Given this list of marker genes PPDPF, CTSD, CDK2, STMN1, HNRNPH3, HLA-DMA, ADD1, S1PR4, RCBTB1, HMCES, MTCH1 (NCBI Gene Id 51627), SUN2, SPA17, DOK2, PIP4K2A, GLIPR2, RAD51AP1, QSOX1, OXCT1, ARMCX2, SPATA13, ACOT9, KIF20A, NHERF1 (NCBI Gene Id 9368), APCDD1, KIF11, USP3, TMEM71, PQBP1, CDKN1B, HSD17B4, CAPG, TCF7, CTSA (cathepsin A), FRAT1, INTS9, CACUL1, VAMP8, FOXC1, ITM2A, PLS3 (NCBI Gene Id 5358), TIMM10B, NSMCE1, SMPDL3A, DDX19B, TRPV2, NCOA5, TMEM50B, NUDT16L1, INCENP, S100PBP, RPA1, NOP53, TLE4, ITGB7, DAP, RNF145, RAMAC, RAC2, ACP6, PDCL3, PLD3, RASA3, MCM2, SERBP1, RGS10, MGST2 (microsomal glutathione S-transferase 2), PROS1, ZNF277, MXD3, HSD17B10, CDADC1, OCEL1, KCNJ8, CASP6, BTBD1, CAVIN3, MYB, LTB, MCOLN2, ID3, XPR1, RPL34, PIK3R1, TBC1D23, CASP7, ENG, NRGN, TWF2, BTK (Bruton tyrosine kinase), TSPAN32, LSP1, CSTB, C19orf12, SARAF, NUCB1, KLKB1, RIPOR2, KDELR1, KLK8, PRKACB, FERMT2, RNF26, RPP21, PEX6, S100A10, PIGX, CCDC28B, GIMAP4, EIF3K, OAZ2, TNFAIP8L1, ARPC3, WBP1L, HDAC5, ANXA5, HCLS1, PDRG1, UBE2L3, HNRNPM, ASF1B, NAA38, UNG, BRK1, BUD31 (BUD31 homolog), GAD2, KLF2, NAP1L1, ORC2, GMFG, UBE2B, MCM5, CTDSP2, TRPC4AP, MTTP, GPSM3, MAP1LC3B, LAPTM5, LMNB1, SEPTIN6, EPHX1, CSNK1G2, FXYD5, AAMP, BUB3, IL17RA, RPL23 (ribosomal protein L23), HPCAL1, POLD4, CMTM3, ENTREP3, FAM107B, EPCAM, MAP4K2, PDLIM1, USP9X, DGKA, ZAP70, STK11IP (NCBI Gene Id 114790), PLXND1, CSDE1, CDCA8, CD9, COX7A2L, TMEM126A, SMIM14, RASSF5 (Ras association domain family member 5), ARL2BP, GNA15, METTL8, MPRIP, RPS5, DLGAP5, RBM38, AKT2, POMP, FAM50A, VPS26C, GCSAM, SYNPO, RMND5A, PJA1, TNNT1, SLC9B2, CNN2, HMOX2, PCLO, NUDT14, EXOC7, FRMD8, CTC1, PHTF1, ARHGDIB, RPS3, NRP1, C12orf57, DYNLRB1, INPP5K, IL1RAP, DIAPH3, here is a description of the gene set: Differentiation of naive CD8 T cells into cytotoxic effector cells requires three distinct signals- antigen (signal 1), costimulation -B7-1 (signal 2) and cytokine, either interleukin-12 or interferon-a/b (signal 3). Interaction of naive CD8 T cells with antigen and B7-1 programs cell division and proliferation whereas the presence of cytokines- IL-12 or IFNa/b promote survival, differentiation and memory establishment. In the absence of signal 3, the cells interacting with antigen/B7-1 undergo tolerance induction. The objective of this study was to elucidate the mechanisms how the provision of signal 3 promotes differentiation and averts tolerance induction in CD8 T cells. Trichostatin A is a pharmacological agent that inhibits histone deacetylase activity, hence regulating chromatin structure and gene expression and differentiation in many cell types. Gene signature profiles of IL-12, IFNa/b and trichostatin A stimulated cells were compared to elucidate the molecular mechanisms of gene regulation. Oligonucleotide microarray analysis is carried out to determine the extent and molecular nature of the CD8 T cell differentiation program induced by IL-12 or IFNa/b in concert with antigen and B7-1 signal. Genes up-regulated in comparison of unstimulated CD8 T cells at 48 h versus CD8 T cells at 48 h after stimulation with antigen-B7-1. species: Homo sapiens from publication Agarwal P, Raghavan A, Nandiwada SL, Curtsinger JM, Bohjanen PR, Mueller DL, Mescher MF (PMID 19592655) Human Gene Set: GSE15930_STIM_VS_STIM_AND_IFNAB_48H_CD8_T_CELL_UP